Given this list of marker genes Snai2, Fgf2, Lgmn, Met, Shh, Prkd2, Vegfa, Fgfr1 (NCBI Gene Id 14182), Fgf18, Hrg, Kdr, Cxcl13, Hspb1 (heat shock protein 1), Prkd1, Sema5a (sema domain, seven thrombospondin repeats (type 1 and type 1-like), transmembrane domain (TM) and short cytoplasmic domain, (semaphorin) 5A), Thbs1, Fgf1 (NCBI Gene Id 14164), Tmsb4x, Smoc2, Fgf16, Fgf4, Notch1, P2rx4, here is a description of the gene set: studied in species Mus musculus Any process that modulates the frequency, rate or extent of endothelial cell chemotaxis. Mouse Gene Set: GOBP_REGULATION_OF_ENDOTHELIAL_CELL_CHEMOTAXIS